Given this list of marker genes CIRBP, UTP23, MRPS6, MAP3K20, RPS3, MRPS18C, RPS13, MRPS18A, here is a description of the gene set: studied in species Homo sapiens Human Gene Set: GOMF_SMALL_RIBOSOMAL_SUBUNIT_RRNA_BINDING Binding to small ribosomal subunit RNA (SSU rRNA), a constituent of the small ribosomal subunit. In S. cerevisiae, this is the 18S rRNA.